Given this list of marker genes KCNJ16, CYP11B2, SLC12A3, HSD3B2, SLC12A1, CYP11A1, SCNN1G, CLCNKA, KCNJ10, NR3C2, SCNN1B (NCBI Gene Id 6338), SLC26A3, CLCNKB, INSR, CASR, BSND, MAGED2, SCNN1A, KCNJ1, here is a description of the gene set: Increased circulating renin concentration An increased level of renin in the blood. species: Homo sapiens Human Gene Set: HP_INCREASED_CIRCULATING_RENIN_CONCENTRATION